Given this list of marker genes PTPN11, POLR1D, PTH1R, POLR1B, IDH2, TCOF1, IFIH1, TREX1, PRKAR1A, ACP5, PDE11A, RNASEH2B (NCBI Gene Id 79621), RNASEH2A, LSM11, COL2A1, MAD1L1, RNASEH2C, ACVR1, POLR1C, RNU7-1, IDH1, ADAR, SAMHD1, here is a description of the gene set: studied in species Homo sapiens A solitary, benign, intramedullary cartilage tumor that is often found in the short tubular bones of the hands and feet, distal femur, and proximal humerus. Enchondroma Human Gene Set: HP_ENCHONDROMA